Given this list of marker genes RHD, AQP6, AQP1, RHCG, SLC12A2, SLC12A5, RHCE, RHBG, RHAG, AQP8, here is a description of the gene set: Human Gene Set: GOMF_AMMONIUM_CHANNEL_ACTIVITY studied in species Homo sapiens Enables the energy-independent facilitated diffusion of ammonium through a transmembrane aqueous pore or channel.